The following is a description of a gene set: Any process that activates or increases the frequency, rate or extent of cAMP/PKA signal transduction. studied in species Homo sapiens Human Gene Set: GOBP_POSITIVE_REGULATION_OF_CAMP_PKA_SIGNAL_TRANSDUCTION, and this is the list of marker genes: ADCYAP1R1, APP, UCN, SPATC1L, CRH, CALCR, IAPP, RAMP3, ADRB2, ADIPOQ, MIF, SCT, MC1R